Given this list of marker genes ZNF683, TRBV28, TRBV2, RPS26, ID2, IFITM3, TRBV4-2, IER2, FGFBP2, TNFAIP3, JUN, NFKBIA, HOPX, HLA-DRB5, ZFP36, GNLY, CXCR4, here is a description of the gene set: Human Gene Set: UNTERMAN_PROGRESSIVE_VS_STABLE_IPF_CD8T_DN Thirty-eight PBMC samples from 25 patients with IPF and 13 matched controls yielded 149,564 cells that segregated into 23 subpopulations. Classical monocytes were increased in progressive and stable IPF compared to controls (32.1%, 25.2%, 17.9%, respectively, p<0.05). Total lymphocytes were decreased in IPF vs controls, and in progressive vs stable IPF (52.6% vs 62.6%, p=0.035). Tregs were increased in progressive vs stable IPF (1.8% vs 1.1% of all PBMC, p=0.007), although not different than controls, and may be associated with decreased survival (P=0.009 in Kaplan-Meier analysis; P=0.069 after adjusting for age, sex, and baseline FVC). Flow cytometry analysis confirmed this finding in an independent cohort of IPF patients. Fraction of Tregs out of all T cells was also increased in two cohorts of lung scRNA-seq. CCL22 and CCL18, ligands for CCR4 and CCR8 Treg chemotaxis receptors, were increased in IPF. The single-cell atlas of the peripheral immune system in IPF, reveals an outcome-predictive increase in classical monocytes and Tregs, as well as evidence for a lung-blood immune recruitment axis involving CCL7 (for classical monocytes) and CCL18/CCL22 (for Tregs). (From Abstract) from publication Unterman A, Zhao AY, Neumark N, Schupp JC, Ahangari F, Cosme C Jr, Sharma P, Flint J, Stein Y, Ryu C, Ishikawa G, Sumida TS, Gomez JL, Herazo-Maya JD, Dela Cruz CS, Herzog EL, Kaminski N (PMID 38717443) species: Homo sapiens Genes downregulated in CD8 T-cells from Progressive Idiopathic Pulmonary Fibrosis Patients vs. Stable Non-Progressors